The following is a description of a gene set: Human Gene Set: REACTOME_SIGNALING_BY_ERBB2 Signaling by ERBB2 species: Homo sapiens, and this is the list of marker genes: AKT3, YES1, EGF, GAB1, HRAS, DIAPH1, PIK3R1, NRG2, NRG3, CUL5, PTPN12, PLCG1, UBB, FYN, UBC, KRAS, GRB2, PRKCE, MATK, AKT2, ERBB3, PRKCD, NRG4, GRB7, STUB1, BTC, ERBB2, UBA52, SOS1, EREG (NCBI Gene Id 2069), RPS27A, PIK3CA, PTPN18, EGFR, PTK6, HBEGF, USP8, SHC1, AKT1, HSP90AA1, PRKCA, NRG1, SRC, CDC37, RHOA, NRAS, ERBB4, MEMO1, RNF41, ERBIN